Given this list of marker genes Hax1, Lsm6, Rnf135, Rps6, Edc4, Trim30a, Rock2, Cpeb1, Patl1, Dcp1a, Tnrc6c, Piwil2, Dcp2, Trim12c, Prrc2c, Dhx30, Helz, Endov, Nanos3, Shb, Lsm1, Uhmk1, Rock1, Myh1 (myosin, heavy polypeptide 1, skeletal muscle, adult, NCBI Gene Id 319292), Ago4, Tubb5, Sympk, Polr2g, Trim5, Psma2, Cirbp, Shfl, Rc3h1, Zc3h12b (NCBI Gene Id 547176), Khnyn, Ogfod1, Tdrd7, Mov10l1, Mcrip2, Habp4, Eif2s1, Ago3, Slc39a2, Ckap5, Ddx1, Ghr, Gabpb1 (GA repeat binding protein, beta 1), Lsm4, Mbnl1, Znfx1, Igf2bp3, Exd1, Tardbp, Ddx3x, Rbpms, Rpl6, Zfand1, Zfp36, Celf1, Pabpc1l, Sarnp, Fastkd5, Dhx36, Larp1, Pabpc2, Ubap2l, Henmt1, Atxn2, Poldip3, Tdrd5, Socs1, Serpinb1b, Noct, Ddx19b, Limd1, Igf2bp2, Upf1, Mex3a, Carhsp1, Slc25a54, Rps6-ps4, Trim12a, Prkaa2, Eif3b, Grb7, Dis3l2, Helz2, Stau1, Rbfox1, Nsun2, Tbrg4, Hnrnpa2b1, Lsm14a, Dcps, Pan2, Trim30d, Dhx9, Edc3, Lin28a, Ddx4, Ctsg, Eif4e2, Rbm4, Fastk, Pabpc1, Cdk9, Pkp1, Ang, Rpl28, Larp4, Ddx19a, Ythdc2, Dazap2, Lsm14b, Tstd1, Cdc42, Cnot9, Trim30c, Pabpc4l, Atxn2l, Bard1, Fxr1, Zc3h12c, Dync1i1, Btbd1, Actb, Vcp, Arc, Smg1, Ddx25, Zar1l, Ythdf2, Apobec3, Trim30b, Fmr1 (NCBI Gene Id 207836), Fastkd1, Tdrd6, Eif4ebp2, Mael, Dcp1b, Eid1, Cnot8, Rpl6l, G3bp2, Pabpc4, Cnot3, Hnrnpu, Mapt, Tdrd9, Qki, Cnot2, Ythdf3, Ybx1, Cnot1, Psmc2, Larp4b, Kmt5b, Smn1, Ythdf1, Hnrnpk, Ankrd34c, Ajuba, Taf5l, Trim21, Igf2bp1, Casc3, Tuba1a, Eif4a1, Rpusd4, Tdrd1, Sqstm1, Serpinb1c, Clock, Fxr2, Gtsf1, Trub2, Kpnb1, Nxf1, Lsm3, Garre1, Mex3b, Tial1, Hnrnpl, Grsf1, Wtip, Rac1, Dyrk3, G3bp1, Pabpc6, Rpusd3, Trim25, Pnrc1, Eif4enif1, Caprin1, Pcbp1 (poly(rC) binding protein 1), Cma1, Trim71, Ctsh, Tdrkh, Asz1, Pan3, Hoxd10, Smg5, Mfsd2a (MFSD2 lysolipid transporter A, lysophospholipid), Rplp0, Ppp6r2, Tnrc6a, Zfp36l1, Stau2, Kif5a, Kpna2, Mir23a, D1Pas1, Rbm20, Piwil1, Ina, Cnot7, Gigyf2, Elavl1, Upf2, Zc3h12a, Nynrin, Mcrip1, Mov10, Pnrc2, Psmc3, Poli, Marcks (myristoylated alanine rich protein kinase C substrate), Bmal1, Ncl, Xrn1, Hnrnpab, Syne1, Fastkd3, Hipk2, Rps4x, Samd4, Tnrc6b, Tut4, Isg20, Pum1, Fam184a, Bpi, Zar1, Iqgap1, Aicda, Psma4, Nbdy, Fastkd2, Sumo1, Psma6, Ddx28, Patl2, Ddx6, Ago1, Serpinb1a, Csde1, Khsrp, Nfkbiz, Snrpb2, Htt, Piwil4, Eif4e, Pum2, Samd4b, Hsf1, Kif3c, Ddx3y, Pqbp1, Btbd2, C9orf72, Usp3, Sncaip, Pabpc5, Eif4g1, Snrpg, Zc3h12d, Hnrnpa3, Nufip2, Rc3h2, Rptor, Tia1, Top1, Ago2, Ssb, Nanos2, Rbpms2, Lsm2, here is a description of the gene set: Mouse Gene Set: GOCC_RIBONUCLEOPROTEIN_GRANULE studied in species Mus musculus A non-membranous macromolecular complex containing proteins and translationally silenced mRNAs. RNA granules contain proteins that control the localization, stability, and translation of their RNA cargo. Different types of RNA granules (RGs) exist, depending on the cell type and cellular conditions.